Given this list of marker genes CLEC7A, GPR183, RNF144B, MS4A4A, RPS24, RNASET2, CTSB, OGFRL1, PTEN, HLA-DOA, FGD2, NAP1L1, HLA-DPB1, FCGR2A, CD83, COTL1, TNFRSF1B, SRGAP2B, C1QC, CELF2, LIPA, CCL3L3, LAPTM5, ADAM28, ATP1B3, SGK1, PLEKHO1, CTSH, ITGAX, FABP5, MFSD1, HLA-DRA, PSTPIP2, HLA-DPA1, CPVL (carboxypeptidase vitellogenic like), IFNGR1, C5AR1, PABPC4, MAFB, PTPRE, THEMIS2, C3AR1, CYBB, FPR1, FGL2, ARRB2, PHACTR1, HLA-DMA, FTH1, MACROH2A1, LIMS1, HLA-DRB5, PLAUR (NCBI Gene Id 5329), LPCAT2, ALOX5, NR4A3, AIF1, S100A11, CALHM6, RTN1 (reticulon 1), NLRP3, RGS10, TNFSF13B, HLA-DQA1, DPYSL2, CYRIB, VSIR, REL, FGR, CD84, RGCC, CCDC88A, SLC15A3, SAT1, POU2F2, RPL36A, EMILIN2, LGALS9, LST1, GRN, TPP1, LRRC25, FCGR2B, SRGN, PLEK, FCGR3A, MRC1, HCK, ATP6V1B2, IL13RA1, SYK, RNF130, KLF4, CIITA, VIM (NCBI Gene Id 7431, vimentin), BCAT1, PKM, SMAP2 (NCBI Gene Id 64744), GPR34 (G protein-coupled receptor 34), AXL, PTAFR, LILRB3, TBXAS1, CD86, IRF8, IER5, STK17B, LILRB4, CLEC10A, PLD4, CPM (NCBI Gene Id 1368), GAPT, CD37, AREG, P2RY13, FCER1G, FPR3, BASP1, RAB31, C1QA, IGSF6, NCOA4, MIS18BP1, LILRB2, CD163, MSR1, ANXA1, SH2B3, CLEC4E, LY86, RNASE6, SLCO2B1, PSAP, MS4A7, PLXDC2, CD1C, HERPUD1, MARCHF1, ADA2, GPX1, AP1S2, CCR1, MNDA, RILPL2, MS4A6A, RBPJ, TMSB4X, NPC2, PABPC1, TLR2, RPS11, IL1B, KLHL6, FCER1A, EVI2B, CXCL8, PARVG, GNAQ, IER3, SAMHD1, CXCL16, HLA-DRB1, FTL, MAP3K8, HSPA6, C1QB, RGS1, TMSB10, CST3, MPEG1, NCF2, IL18, F13A1, ITGB2, KCTD12, VSIG4, HCLS1, HLA-DMB (NCBI Gene Id 3109), FCGBP, LYN, WDFY4, TGFBI, HLA-DQB1, ARPC3, TYROBP, JARID2, JAML, PPT1, RGS2, ROCK1, SRGAP1, C1orf162, AHR, UCP2, LYZ, IL1R2, CSF1R, LGALS1, CTSS, ARPC1B, here is a description of the gene set: from publication Aizarani N, Saviano A, Sagar, Mailly L, Durand S, Herman JS, Pessaux P, Baumert TF, Grün D (PMID 31292543) studied in species Homo sapiens Human Gene Set: AIZARANI_LIVER_C2_KUPFFER_CELLS_1